Given this list of marker genes Wipi2, Atg16l1, Irgm2, Igtp (interferon gamma induced GTPase), Irgm1, Atg5, here is a description of the gene set: Mouse Gene Set: GOBP_C_TERMINAL_PROTEIN_LIPIDATION The covalent attachment of a lipid group to the carboxy-terminus of a protein. species: Mus musculus